The following is a description of a gene set: studied in species Homo sapiens Sensory behavioral abnormality Abnormal sensory behavior, including avoiding or seeking sensory input or difficulty modulating sensory stimuli. Human Gene Set: HP_SENSORY_BEHAVIORAL_ABNORMALITY, and this is the list of marker genes: RP1L1, IL23R, KRT3, RLBP1, PRPF4 (pre-mRNA splicing tri-snRNP complex factor PRPF4), DHX38, AP1B1, GUCA1B, POLA1, CRX, RNU4-2, TULP1, HK1, COL17A1 (collagen type XVII alpha 1 chain), MPLKIP, ESR1, GTF2H5, CST6, TEK, PROM1, BBS7, DCN, CNGA3, STX1A, ZEB1, RP1, USP45, KLHL7, TNF, GDF6, BBS9, UBE3A, KCNJ13, CLCC1, ARHGEF18, USH2A, TRANK1, KCNV2, NLRP3, CRLS1, UBA2, SCLT1, ALMS1, KIAA1549, RHO, ERCC2, SDCCAG8, CABP4, DNAJC30, FOXC1, PRPF3, UBAC2, CEP250, CLIP2, BBIP1, SLC39A4, ITM2B, MEFV, ARL2BP, KLRC4, NOTCH2NLC, MYT1L, AP3B1, TACSTD2, RDH12, NLRP1, NRL, SQSTM1, IFT88, FAM161A, PRKAR1B, TGFBI, PDE6B, ERAP1, PCNA, HGSNAT, ATXN7, OVOL2, PRCD, GTF2E2, TOPORS, CEP78, SEMA4A, ERCC4, BEST1, UNC119, AHSG, RBP3, TTLL5, ADAM9, POMGNT1, RGS9BP, SLC7A14 (NCBI Gene Id 57709), HLA-A, OPN1MW, NEK2, BMS1, RPE65, BBS5, CEP290, CDHR1, MFRP, MC1R, TMEM106B, RGS9 (regulator of G protein signaling 9), SLC1A3, RGR, FKBP6, PPM1D, ROM1, CFI, ERCC3, IMPDH1, PDE6G, RFC2, MLXIPL, IDH3B, ITGB6, IFT172, GRN (granulin precursor), BBS12, RIMS2, AIPL1, IFNGR1, MFF, SCN1A, PCARE, PRPF8, MYOC, ANTXR1, GJA1, POC1B, BBS2, CACNA1F, LRAT, LIMK1, RIMS1, IFT27, TUBB4B, PIKFYVE, GJB2, VCP, CNGB3, TLR4, PAX6, CYP1B1, CARS1, TTC8, HLA-B, NR2E3, CLTRN, CTNS, CC2D2A, HADHA, IL10, NAA60, HARS1, HPS1, ABCA4, DDB2, ZNF408, GRHL2, SLC6A19, GPR143, RDH5, FLII, KRT12, ARL6, HEXB, PSEN1, AFG3L2, NOD2, GTF2I, GUCA1A, POLH, RD3, AGBL5, SREBF1, PCYT1A, CDKL5, LCA5, TYR, NSUN2, CLRN1, SNRPN, RNF113A, C4A, RAB28, SLC24A5, ERCC6, MAK, TREM2, DHDDS, NMNAT1, ARL3, SLC45A2, GM2A (ganglioside GM2 activator), BBS4, TRIM32, IFT140, SPATA7, GUSB, TP63, ITGB4, IL12A, ALDH3A2, WNT10A, PLCD1, PLEC, FZD5, GAN, MKKS, CNGB1, TUB, SAG (S-antigen visual arrestin), HLA-DRB1, CNGA1, STAT4, IQSEC2, GNB3, ATP10A, COL8A2, NCF1, DLL4, AUTS2, RPGR, BLOC1S5, CFAP418, ERCC8, RP9, XPC (XPC complex subunit, DNA damage recognition and repair factor), RAX2, PRPH2, IDH3A, AARS1, PERCC1 (NCBI Gene Id 105371045), ERCC5, PRPF31, GTF2IRD1, CEP19, PNPLA6, ATF6, BUD23, XPA, EFEMP1, TMEM270, MKS1, GJB6, CFH, TRIM44, PSAP, WDPCP, BAZ1B, LYST, KRT14, WDR45, OFD1, TIMM8A, PDE6H, OPN1SW, RFX7, AP3D1, ELN, TAF4, RP2, RAI1, PDE6A, MCAT, RTN4IP1 (NCBI Gene Id 84816), EDNRA, METTL27, GTF2IRD2, INPP5E, NPHP1, COL4A1, OCA2, CFAP410, DCTN1, LTBP2, CRB1, ELOVL1, DKK1, CHST6, TLCD3B, EPCAM, PRPF6, CCR1, LSS, FOXC2 (forkhead box C2), MBTPS2 (NCBI Gene Id 51360), TAT, ZNF513, PRNP, SHANK3 (SH3 and multiple ankyrin repeat domains 3), MCOLN1, KIZ, KRT5, BBS10, AIRE, PDE6C, LIG4, AHR, CRYGC, VPS37D, FSCN2, IMPG1, CNNM4, LZTFL1, GALC, TRIO, CACNA2D4, CREBBP, UBAP2L, PTPN22, IL12A-AS1, ELOVL4, OPN1LW, IKZF1, FAS, IMPG2, DRAM2, C1QTNF5, DEAF1, LRMDA, MERTK, ST14, AHI1, CERKL, ERCC1, GNAT2, REEP6, TBL2, MAPT, PITPNM3, CHMP2B, BBS1, EIF4H (eukaryotic translation initiation factor 4H), DCT, TARS1, IQCB1, RPGRIP1, EYS, SNRNP200, IFT74, CA4, GUCY2D, SCAPER (NCBI Gene Id 92909), EP300, VSX1, HPS6